The following is a description of a gene set: A preribosomal complex consisting of 20S pre-rRNA, ribosomal proteins including late-associating small subunit proteins, and associated proteins; a precursor of the eukaryotic cytoplasmic small ribosomal subunit. Human Gene Set: GOCC_PRERIBOSOME_SMALL_SUBUNIT_PRECURSOR studied in species Homo sapiens, and this is the list of marker genes: RIOK3, FTSJ3, UTP20, RIOK1, RIOK2, NOB1, LTV1, BYSL, NOP9, SLX9, NOC4L, RRP1B, RRP1 (ribosomal RNA processing 1), NOP14